Given this list of marker genes MYF5 (NCBI Gene Id 4617), FHL2, FAM13A, KIF24, NDST3, ZKSCAN8, CKMT2, WDR1, RBM5, VWA8, CCNG1 (NCBI Gene Id 900), IFNA7 (NCBI Gene Id 3444), GPD1, SLCO1B1 (NCBI Gene Id 10599), POMZP3, NOD2, GNAT3, SSTR2, CSPP1, SLC38A4, ZMAT4, ZNF654, ZFYVE16, DEFA6, HTR1B, RLF, SLC9A8, USP46, ALPK3, RGS17, SP140L, CAST, PTGIR, SP140, N4BP2L2, KITLG, FCHSD2, NPIPB15, SNAP25, NEFL, CLDN4, DNAL4, LIPT1, TMEM168, BPESC1, CDCP1, DMXL1, EPHX2, IFNA1, EML4, KRT75, TMEM242, ZNF254, RPL23AP53, MED18, KLF6, CYP2B7P, IMPACT, ESR1, BMP15, ENSG00000289047, KCNQ1DN, ADD3, BPHL, GATC, FUCA1, KANK1, OPCML, TMPRSS2, FRAT1, PGAP3, HLA-F-AS1, TOX, CEP295, PRKAB2, SRP9, ZNF606 (NCBI Gene Id 80095), MMP11, SMIM27, ZNF35, NOS3, H3C1, NAP1L2, ADIRF, CCKAR, BLTP1, TAP2, AGBL2, PNRC2, ADAM3A, RPL23A, AKAP10, PPP1CB, CIT, UBAC1, COL6A1, MAFK, GLIPR1, ZNF589, PNISR, NDC80, ELN, PCDHGA10, CXCL5, ADTRP, TASL, SURF1, DMTF1, NR3C2, BNIP3L, ZNF407, NHLRC2, GALC, NKX2-8, HMGB1, MAFB, IFT46, NPEPPSP1, RAD23B, ENTPD4, TFB1M, PHLDB1, CSF2RA, CD55, NFKB2, NBAS, CCDC30, CARMIL1, STAP1, IL25, P2RY10, NXPH4, PTCH1, GATB, IKBKB, PLEKHF1, KBTBD11, CBX7, RAD21, UPK1A, SH2B3, FKBP14, C1D, SLC3A1, CCS, DROSHA, AASS, DNASE1L2, LARP6, NEMP1, PDSS2, LYRM2, EPM2AIP1, ACE, LRRK1, EXOSC10, FRYL, B3GAT1, USP27X, FAM30A, ZNHIT1, NUCB2, SYN1, HADH, NFU1, CTSE, EGFL6, KLRC4, H2BC9, AMELX, BAZ1A, PPP1R3C, CCNG2, FHIT, CEP83, NDST4, WDR19, PSIP1 (NCBI Gene Id 93428), ENOX2, ATP5F1E, SH3BGRL, TRAPPC10, PRICKLE3, SYNJ2BP, INSRR, MBNL1, KIFC1, PTPN22, REEP4, CBX4, NELL2, CXCR4 (NCBI Gene Id 93405), MGAM, SCRT1, CSN2 (NCBI Gene Id 1447), NME8, COL10A1, here is a description of the gene set: With increasing age, the ability of the immune system to protect against recurring infections or to control chronic infections erodes. The objective of the current study was to identify gene expression signatures in elderly CD4 T cell responses Human Gene Set: GSE36476_YOUNG_VS_OLD_DONOR_MEMORY_CD4_TCELL_16H_TSST_ACT_DN Genes down-regulated in comparison of memory CD4 T cells from young donors treated with TSST at 16 h versus those from old donors treated with TSST at 16 h. studied in species Homo sapiens from publication Yu M, Li G, Lee WW, Yuan M, Cui D, Weyand CM, Goronzy JJ (PMID 22434910)